The following is a description of a gene set: Any process that modulates the frequency, rate or extent of EGF-activated receptor activity. Human Gene Set: GOBP_REGULATION_OF_EPIDERMAL_GROWTH_FACTOR_ACTIVATED_RECEPTOR_ACTIVITY studied in species Homo sapiens, and this is the list of marker genes: SOCS4, ERRFI1, SNX6, SOCS5, ZGPAT, GPRC5A, CHMP6, ADAM17, TSG101, ZFYVE28, VPS25